Given this list of marker genes LGR6, KLHL21, C11orf58, SELENOW, URGCP, DNMBP, SLA, TMEM14A, NNMT, MGAT1, RAB5B, NDUFA1, NF2, BAG4, MAST3, ABHD6, GLRX, SLC25A19, LRPAP1, PAQR3, ZFAND2A, ISCA1, SPATS2 (NCBI Gene Id 65244), SLC2A4RG (NCBI Gene Id 56731), PCID2, PRDX2, OSBPL7, PPARA, KLHDC8B (kelch domain containing 8B), BNIP3, CTBS, IGF2R, CD247, SKAP1, NDUFAF4, NDUFA12, SHISA5, CYBA, BOLA3, CHMP2A, DEF8, BABAM1, PRR13, LSS, FAM53B, MIR646HG, GPATCH3, HMGN2, BRK1, EP400P1, MED7, ZNF682, TGFBR1, RAB6A, MAT2B, NDUFB4 (NCBI Gene Id 727762), YKT6, ATP6V1E1, IFI27L2, SMPD1, ZEB2, PRNP, NDUFB5, ELP6, IGFBP7, ATP5PD, PDCD2, SLC15A4, LYN, MICOS10, SLC39A14 (NCBI Gene Id 23516), THBS4, GIMAP4, TERF1, MXI1, LINGO2, PSMA2, TGFBR3, ADIPOR2, GNS, SH3BGRL3, MRPL1, OST4, SNAPC3, ITM2B, SERPINI1, PMS1, SRSF7, CASP1, ITGB2, TMEM9B, UQCRFS1, CCDC88C, YPEL2, CAP1, CAMK2N1, TOGARAM2, LAMTOR2, ZNHIT1, ZRSR2, RSU1 (NCBI Gene Id 6251), SLC39A11, TMED3, LPCAT1, ACOT8, COMMD9, STIM1, MGST3, PTPN18, SAP18, TSPYL2, PRDM1, ZNHIT3, PPP2R5D, COX7B, NUDT1, YARS2, HCLS1, RABIF, CA11, C18orf32, POP4, RHOC, PRKCH, CARINH, LINC02481, TFIP11, BTBD6, HEXIM1, SGPL1, SUPT4H1, PMM1, HEXB, ZNF622, ATP1B3, EPC1, PRKCA, GAR1, PPP6R1, ONECUT2, MIEN1, ITGB7, LAMP1, KIR3DL3, LIPT1, PCGF6 (NCBI Gene Id 84108), HNRNPA3P1, SUSD1, SLC43A3, ELOC, CLPTM1L, IL32, DGUOK, TMED2, ABHD14A, RETREG2, CPD, CAPN2, TSPAN31, BCL10, PCED1B-AS1 (PCED1B antisense RNA 1), BTD, PLOD1, NTAN1, UBB, ATP6V1A, DUSP28, POP7, MYL12B, ATP5MK, DTX3, PHPT1, KAT2B, TAF4, TKTL1, OR1D2, USE1, TMEM160, ARHGAP27, SESN2, PIF1, ZNF335, KIR2DS4, RNF139, NDUFS7, LRRC10B, MYH9, SCAMP3, SOD1, WDR47, PTS, C3AR1, TGFB1, RNF213, WDR45, AGPAT3, OBI1 (NCBI Gene Id 86572), SFT2D1, GRAMD2B, here is a description of the gene set: Human CD14 positive monocytes were purified from healthy volunteers’ blood and cultured in vitro for 4, 12, 24, 72 hours. While culturing, macrophages were activated alternatively with interleukin-4 (IL-4 100 ng/ml) or classically with interferon-gamma (IFNg 100 ng/ml)+tumor necrosis factor (TNF 50 ng/ml) or left without activation. Simultaneously, macrophages were also treated with vehicle (DMSO:ethanol) or 1mM synthetic PPARg agonist, Rosiglitazone. We used Affymetrix microarrays (U133Plus 2.0) to analyze activation and PPARg-induced gene expression changes. Human Gene Set: GSE16385_IFNG_TNF_VS_IL4_STIM_MACROPHAGE_ROSIGLITAZONE_TREATED_DN species: Homo sapiens Genes down-regulated in macrophages (12h): IFNG, TNF and rosiglitazone versus rosiglitazone and IL4. from publication Szanto A, Balint BL, Nagy ZS, Barta E, Dezso B, Pap A, Szeles L, Poliska S, Oros M, Evans RM, Barak Y, Schwabe J, Nagy L (PMID 21093321)